The following is a description of a gene set: studied in species Mus musculus RNA Polymerase I Transcription Termination Mouse Gene Set: REACTOME_RNA_POLYMERASE_I_TRANSCRIPTION_TERMINATION, and this is the list of marker genes: Gtf2h1, Polr1c, Polr1f, Gtf2h4, Polr2k, Taf1a, Ercc2, Polr1e (NCBI Gene Id 64424), Polr1g, Taf1b, Gtf2h3, Polr2h, Polr2l, Cdk7, Polr2f, Taf1c, Polr1b, Mnat1, Polr1a, Gtf2h2, Ccnh, Tbp, Polr2e (polymerase (RNA) II (DNA directed) polypeptide E), Gtf2h5, Taf1d, Ubtf, Ercc3, Ttf1 (transcription termination factor, RNA polymerase I), Polr1h (RNA polymerase I subunit H), Cavin1